Given this list of marker genes AP1G1, FAM13B, FCHSD2, COL1A1, PTPRM (protein tyrosine phosphatase receptor type M), EPB41L1, ACTR3, KIF1B, PFKFB4, WDR26, PNN, C1orf21, SV2A, ACSL4, CPEB4, FZD4, TAPT1, FOXO4, MAFK, UBE2A, RBBP7 (NCBI Gene Id 5931), HTR2C, KIF3B, ROBO1, PAX2, CAMK2A, WT1-AS, GOLM2, EFNB2, BCL11B, RNF38, PHLDA3, AMMECR1L, B4GALT2, PDE7B, NR4A2, ATP11A, NR3C2, PAX6, OGDH, RNF111, CALD1, MAPK14, MECP2, MYLIP, FNDC3A, SYT7 (NCBI Gene Id 9066), LGI1, DLX3, RP2, RSBN1, KLF12, KPNA3, CHD9, DPP10, MRPL17, RFX1, KCNMA1 (potassium calcium-activated channel subfamily M alpha 1), RAP1GAP2, AMER2, ZBTB4, SET, COL19A1, SENP7, NCALD, RAB33B, FYTTD1, PAN3, MBNL1, SFMBT1, KCNIP2, SEPTIN11, SEC11A, MEF2D, ZFPM2, GNAT1, PLCB1, DAG1, AEBP2, SPEN, FOXJ2, HMBOX1, TARDBP, SREK1IP1, ULK1, MORF4L1, WDR47, SALL1, ANTXR2, CDK13, PIANP, ULK2, TEAD1, MEMO1, GADD45A, RPP14, PBRM1, MMP24, ARPP19, WIPI2, PRC1, CRISPLD2, TCF12, KCNS2, ACTR10 (NCBI Gene Id 55860), TBX15, ACVR1, AKIRIN1, ADD2, SPTSSB, UBALD1, OCRL, FAM78B, CCDC82, MARCKS, RPS6KB1, HARS2, PABPN1, NSG1, MIER3, UBFD1, UBE2D2 (ubiquitin conjugating enzyme E2 D2), TNRC6B, CACUL1, PAFAH1B2, DCLK1, ARK2C, PTEN, BICD2, WNT3, TBC1D19, IDH3A, EGR3 (early growth response 3), PHF6, SMARCA2, SLC35A3, CREB3L2, MKNK1, OTUD4, SOX21, SLC35D1, NCKIPSD, PITX1, NFASC, TACC1, POU4F2, SOX11, PRKCA, RAB8B, CBX7, API5, FUT4, CORO1C, KPNA4, SRGAP3, VPS13A, SRSF7, ADRA2B, TNRC6A, NOVA1, MBNL2, ARPC2, NDRG1, ZNRF2, ENPP5, LPCAT4, SEPTIN6, TRIM23, RHOB, GGT7, CACNA1E, KMT5B, IVNS1ABP (influenza virus NS1A binding protein), ARID4B, SOCS3, L3MBTL3, PUM1 (NCBI Gene Id 9698), ESRP2, DSCAM, PRKD1, FRMPD4, BNC2, HBP1, USP12, ZNF532, KDM2A, DAPK2, SEMA6D, MAPRE1, DHX40, RAP1A, MEF2C, MAP3K14 (mitogen-activated protein kinase kinase kinase 14), DNAJA2, CNOT7, MYLK4, CHST11, PMEPA1, KLHL13 (NCBI Gene Id 90293, kelch like family member 13), MCU, SAMD4A, GNPTAB, PPP2R5E, PLEC, CADM4, LIMD2, PTGFRN, ADGRG2, CHIC2, NUDT4, GPR85, SRPK2, EPB41L4B, ZCCHC17, HAP1, HSPA14, RUNX3, STK38, RTN2, MYCN, ZEB2, DTNA, PTK2B, ANKRD12, ZNF800, IMPDH1 (NCBI Gene Id 6105), ATXN1, PLXNA2, HOXA13, STAG2, GCG, ZIC1, NBEA, SATB2, NAA30, here is a description of the gene set: Human Gene Set: CTTTGCA_MIR527 studied in species Homo sapiens Genes having at least one occurence of the motif CTTTGCA in their 3' untranslated region. The motif represents putative target (that is, seed match) of human mature miRNA hsa-miR-527 (v7.1 miRBase).